The following is a description of a gene set: Any process that modulates the frequency, rate or extent of calcium ion import across plasma membrane. studied in species Mus musculus Mouse Gene Set: GOBP_REGULATION_OF_CALCIUM_ION_IMPORT_ACROSS_PLASMA_MEMBRANE, and this is the list of marker genes: Ppp3ca, P2rx1, Adrb2, Ppp3r1, Adrb1, Agtr1a, Ppp3r2, Ms4a1, Grm6, Akap5, Ppp3cc, Cav1, Kcnn4, Ppp3cb, Fyn, P2rx5, Prnp